The following is a description of a gene set: studied in species Homo sapiens Human Gene Set: MODULE_233 Genes in the cancer module 233., and this is the list of marker genes: PAICS, UBE2A, UBE2V2, UBR5, UBE2N, UBE2L6, UBE2G1, UBE2H, UBE2D1, UBE2K (NCBI Gene Id 84819), UBE3C, UBE2D3, GCLM, TTLL1, UBE2M, GSS, UBE2L3, UBE2V1, UBE2I, UBE2D2, TRIP12, UBE2S